Given this list of marker genes HSD3B1, LHB, HSD3B2, CGA, CYP21A2, CYP11B2, here is a description of the gene set: studied in species Homo sapiens part of: Metabolism of steroid hormones Reactome Pathway: Mineralocorticoid biosynthesis Aldosterone, the major human mineralocorticoid, is synthesized in the zona glomerulosa of the adrenal cortex from pregnenolone. Pregnenolone is converted to progesterone in two reactions, both catalyzed by 3-beta-hydroxysteroid dehydrogenase/isomerase. Progesterone is hydroxylated by CYP21A2 to form deoxycorticosterone, which in turn is converted to aldosterone in a three-reaction sequence catalyzed by CYP11B2.